Given this list of marker genes GATAD2B, FXN, FOXP2, GRIN2A, SATB2, SRPX2, YME1L1 (YME1 like 1 ATPase), CC2D1A, here is a description of the gene set: studied in species Homo sapiens Human Gene Set: HP_INCOMPREHENSIBLE_SPEECH Incomprehensible speech